The following is a description of a gene set: PDGFRA is mutated in ~10% of gastrointestinal stromal tumors in a mutually exclusive manner with KIT mtutations. In contrast to KIT, PDGFRA GIST mutations occur more frequently in the activation domain, rather than the juxtamembrane domain. In addition to GIST, PDGFRA is subject to missense or small in-frame deletion mutations in haematological cancers and melanoma. In contrast, missense mutations in PDGFRB are rare. Both PDGFRA and PDGFRB are also subject to oncogenic translocation events leading to the expression of fusion proteins.<br>Imatinib is a type II TKIs that is approved as first-line treatment of KIT- and PDGFR-driven tumors; however secondary mutations frequently contribute to the development of imatinib resistance. These secondary mutations further shift the equilibrium of the receptor toward the activated state, making imatinib and even approved second-line type II TKIs less effective. In consequence, considerable effort is devoted to discovery of type II and, in particular, type I TKIs that are active against highly activated PDGFR alleles. part of: Signaling by PDGFR in disease Reactome Pathway: Drug resistance of PDGFR mutants species: Homo sapiens, and this is the list of marker genes: PDGFRA